Given this list of marker genes Pitpnb, here is a description of the gene set: electronically inferred by orthology from the curated human pathway Reactome Pathway: PI and PC transport between ER and Golgi membranes studied in species Mus musculus This event has been computationally inferred from an event that has been demonstrated in another species.<p>The inference is based on the homology mapping from PANTHER. Briefly, reactions for which all involved PhysicalEntities (in input, output and catalyst) have a mapped orthologue/paralogue (for complexes at least 75% of components must have a mapping) are inferred to the other species. part of: Glycerophospholipid biosynthesis; PI Metabolism